The following is a description of a gene set: Human Gene Set: GOCC_ACTIVIN_RECEPTOR_COMPLEX studied in species Homo sapiens A protein complex that acts as an activin receptor. Heterodimeric activin receptors, comprising one Type I activin receptor and one Type II receptor polypeptide, and heterotrimeric receptors have been observed., and this is the list of marker genes: ACVR1C, ACVR1B, ACVR1, ACVR2A, TGFBR1, ACVR2B, TGFBR2